Given this list of marker genes PROM1, CBLN2, MIR6772, DUSP6 (dual specificity phosphatase 6), SRL, LINC01134, LINC01250, FGF18, MIR6075, WNT9A, PRSS38, LPCAT1, EGR2, FOXB1, LINC00954, TPO, TTC7B-AS1, DOK5, MIR5008, DMRTA2, IL17C, IGFN1, INSR, ENSG00000253726, LINC02907, CIB4, PAH, CNKSR3, ADGRF1, ENSG00000231964, C14orf180, KCNK9, DSCAML1, TMEM63A, NTSR2, MIR95, DEPTOR, RNF183, TMEM61, ATP2A3, EPAS1, CD300A, FAM83A, ADCY5, MBOAT1, SATB1, OPRD1, ABTB2, LINC01346, EYA1, NUP210, SOBP, NKAIN2, CABLES1 (NCBI Gene Id 91768), TFCP2L1, SNAI3 (snail family transcriptional repressor 3), MROH1, LINC01234, MIR6081, LINC01267, EPB41L4B, NRON (NCBI Gene Id 641373), SLC6A20, BEAN1-AS1, FAM167A, XKR6, DLGAP1-AS2, PROSER2-AS1, RIMS2, DBH-AS1, SPATA13, SLC35D3, PLXNA2, LRTM2, LPIN1, FBN3, SLC6A6, RET, LRRN4, C1orf127, ELFN1-AS1, SFTA3, MIR4740, ZACN, GPR142, SLC6A3, BEND7, B3GNT8, RALYL, MMP16, LOXHD1, NFATC2, PAX5, KASH5, LINC00511, SH2D4B, BMP8A, MIR153-2, SLC35F3, KISS1R, TRIM67, PLXND1, SEMA5B, ELOVL3, CHGA, CAND2, EPHB1 (EPH receptor B1), HRC (histidine rich calcium binding protein), EPOR, MYRIP, BAIAP3, GRIN2C, TNS1, KIFC3, LINC02870, DLL4, LOXL4, MICAL2, ST6GAL2, JAKMIP1, PNMA3, GTSF1L, GRID1, TMEM181, SMPD3, AVPR1B, MFSD9, PAX9, MIR4257, ARHGAP4 (Rho GTPase activating protein 4), SLC45A4, KIF26A, NPTX1, SCIN, PCBP3, GFI1, TMEM30B, LGR5, AMER3, MUC5B, ANO9, SLC26A9, GPR137B, LMO3, MIR4641, SSTR5, RASGEF1A, GRM4, ATP2C1, UTS2R, MIR4689, RASSF5, CSF3R, MYLK-AS1, ZNF621, GFRA4, MGLL, MIR3164, LINC01276, here is a description of the gene set: from publication Nouruzi S, Ganguli D, Tabrizian N, Kobelev M, Sivak O, Namekawa T, Thaper D, Baca SC, Freedman ML, Aguda A, Davies A, Zoubeidi A (PMID 35477723) Genes bound by ASCL1 in prostate cancer cell lines, and up-regulated in ASCL1 positive patient-driven xenografts. We performed ChIPseq analysis on ASCL1 positive neuroendocrine prostate cancer cell lines 42D-ENZR and two sets of NCI-H660 as well as in LNCaP cells overexpressing ASCL1. Several thousand ASCL1 binding sites were identified following analysis of each ChIPseq. A total of genes annotated to ASCL1 were found common among the four samples. We identified ASCL1 binding at bona fide ASCL1 regulated genes such as INSM1, ID4, HES6, CHGA and DLL4. Integrated ASCL1 ChIPseq data with transcriptomics (RNAseq) data, to identify a consensus ASCL1 transcriptome, we utilized RNAseq from publicly available ASCL1 (+) vs ASCL1 (?) patient driven xenografts from Labreque et al, 2019. 160 ASCL1-bound genes identified in prostate cancer ChIPseq studies also exhibited significantly higher mRNA expression (log2FoldChange?>?2) in the ASCL1 (+) compared to ASCL1 (?) LuCaP PDXs. These genes represent targets of ASCL1, where expression is likely directly regulated by ASCL1 binding. Human Gene Set: NOURUZI_NEPC_ASCL1_TARGETS studied in species Homo sapiens